The following is a description of a gene set: Genes predicted to be targets of miRBase v22 microRNA mmu_miR_8097 in miRDB v6.0 with MirTarget v4 prediction scores > 80 (high confidence targets). from publication Chen Y, Wang X (PMID 31504780) Mouse Gene Set: MIR_8097 studied in species Mus musculus, and this is the list of marker genes: Enpep, Il23a, Kcnb1, Xlr4b, Gne, Pfkfb2, Coa3, Haus2, Rad54l2, Crebrf, Tshz1, Maml1, Nr4a2, Prr18, Faxc, Rgs20, Maged1, Scn7a, Rnf111, Zfp40, Zfp609, Trafd1, AI987944, Map3k12, Zfp654, Kmt2a, Smndc1, Ktn1, Irs1, Smg1, Cdkn1b, Cd163, Zfp788, Lef1, Pdha1, Crabp2, Ankrd50, Six3, Cntln, Fpgt, Dcx, Pxdn, Kif2a, Usp32, Epb42, Ankrd12, Grip2, Depdc5, Arrdc3, Nr2f2, Pcdh9, Aatk, Tgoln1, Angel1, Btg1, Dop1b, Med19, Rnf138, Dazl, Clca3b, Nipbl, Kbtbd6, Kpna4, Stam, Rnf146, Xlr4c, Smc2, Acp1, Scn9a, Edem3, Nck1, Xlr4a, Pdgfc, Prnd, Zc3h12c, Dnaaf6rt, Cyp51, Rprd1b, Upf3b, Kif11, Nbeal1, Zeb1, Meox2, Celf4, Gskip, Coro2a, Tet3, Cadps2 (NCBI Gene Id 320405), Adam10, Cnot7, Epb41l3, Arhgap42, Dusp6, Gpc1, Furin, Vgll3, Rcan2, Ago3, Ephb4, Gm4297, Rap2b, Gm5934, Ift122, AW146154, Olig3, Loxhd1, Nfe2l1, Arid4b, Sp1, Ubn1, Gsk3b, Rfx3, Kat6a, Mcc, Bmal1, Magt1, Ppm1a, Tnrc6b, Brs3, Magea13, Stx16, Opn1mw, Wapl, Boc, Kmt5b, Wbp11, Adam28, Glrb